The following is a description of a gene set: species: Homo sapiens Shoulder girdle muscle weakness Human Gene Set: HP_SHOULDER_GIRDLE_MUSCLE_WEAKNESS The shoulder, or pectoral, girdle is composed of the clavicles and the scapulae. Shoulder-girdle weakness refers to lack of strength of the muscles attaching to these bones, that is, lack of strength of the muscles around the shoulders., and this is the list of marker genes: VCP, GNE, SCN4A, ITGA7, MATR3, POLG2 (DNA polymerase gamma 2, accessory subunit), FRG1, LRIF1, AK9, HNRNPDL, DYSF, RAPSN, TNNT1, RRM2B, MYH7, TRIM32 (tripartite motif containing 32), LRP4, PLIN4, SLC25A4, DNA2, RYR1, COL13A1, ABHD5, MT-TE, DNAJB6, TNPO3, TPM2, TPM3, ANO5 (NCBI Gene Id 203859), GALC, SMN1, GYG1, MYL2, CHRNE (cholinergic receptor nicotinic epsilon subunit), GDAP1, BICD2, AGRN, CHRNA1, TWNK, MUSK, SELENON, FKRP, CHRND, POLG, SMN2, TTN, PNPLA2, MAP3K20, ACTA1, CFL2, PSAP, DOK7, CHRNB1, CRYAB, MYOT, COL6A3, HACD1 (NCBI Gene Id 9200)